The following is a description of a gene set: species: Homo sapiens Tumor growth is associated with a profound alteration of myelopoiesis, leading to recruitment of immunosuppressive cells known as myeloid-derived suppressor cells (MDSCs). Analyzing the cytokines affecting myelo-monocytic differentiation produced by various experimental tumors, we found that GM-CSF, G-CSF, and IL-6 allowed a rapid generation of MDSCs from precursors present in mouse and human bone marrow (BM). BM-MDSCs induced by GM-CSF+IL-6 possessed the highest tolerogenic activity, as revealed by the ability to impair the priming of IFN- -producing CD8+ T cells upon in vivo adoptive transfer. Moreover, adoptive transfer of syngeneic, GM-CSF+IL-6-conditioned MDSCs to diabetic mice transplanted with allogeneic pancreatic islets resulted in long term acceptance of the allograft and correction of the diabetic status. Cytokines inducing MDSCs acted on a common molecular pathway. Immunoregulatory activity of both tumor-induced and BM-derived MDSCs was entirely dependent on C/EBP transcription factor, a key component of the emergency myelopoiesis triggered by stress and inflammation. Adoptive transfer of tumor antigen-specific CD8+ T lymphocytes resulted in therapy of established tumors only in mice lacking C/EBP in myeloid compartment. These data unveil another link between inflammation and cancer and identify a novel molecular target to control tumor-induced immune suppression. We used gene expression analysis to identify those factors, secreted by tumor-infiltrating MDSC, which could drive emathopoiesis. Moreover we compare gene expression profile of tumor-induced MDSC, obtained from either the spleen and the tumor infiltrate of tumor bearing mice, and in vitro bone marrow-derived MDSC. from publication Marigo I, Bosio E, Solito S, Mesa C, Fernandez A, Dolcetti L, Ugel S, Sonda N, Bicciato S, Falisi E, Calabrese F, Basso G, Zanovello P, Cozzi E, Mandruzzato S, Bronte V (PMID 20605485) Human Gene Set: GSE21927_SPLENIC_C26GM_TUMOROUS_VS_BONE_MARROW_MONOCYTES_DN Genes down-regulated in CD11b+ cells from spleen of BALB/c mice bearing C26GM colon carcinoma versus CD11b+ cells from bone marrow of healthy BALB/c mice., and this is the list of marker genes: HS3ST3B1, SLC7A7, SCLT1, NDUFA3, MIF-AS1, C11orf68, MARCHF11, DENND2C, BASP1, MED21, TMTC4, ANKRD46, ORC4, BCL2L1, DNAJB12, TPGS2, XYLT2, ZNF558, POMGNT2, GRIN2B, CTNNA2, CEP164, PPP1CC, FOXN3, CD1D, GLRX5, FOXP1-IT1, CYBC1, ISG15, FRG1, GAB3, NUBP1, LHPP, USP4, PAK1IP1, PREP, NPHP3, SCAMP1-AS1 (SCAMP1 antisense RNA 1), GAPDHP62, RNGTT, BCS1L, RIMBP2, LIMS2, IFNAR1, KCNMB4, NPM3, CRELD1, GOLGA5, CECR7, ZFAND2A, GPR160, PALD1, ZFP82, NENF, FDX1, PLEKHG2, NEK8, C8orf33, NOS3, UTP18, ABI1, STAG3L4, SGK1, MTRES1, SLC4A7 (solute carrier family 4 member 7), DUSP3, FAM149B1, LIPA, NOP2, MRM2, ZNF521, NFIL3, ZNF790-AS1, SPMIP1, HINT1, HENMT1, NOTCH2NLA, ARHGAP26, MGST3, TMEM238, TNFRSF21, NXPH4, UBTD2, BHLHE40, SNRNP25, C10orf88, IFT52, SPATS2, FNTA, DDX31, CSRP1, FXN, NFATC2IP, ALDH18A1, RIMS3, DNAJB6, MAP3K20, NREP, CNFN, LSP1, CCDC97, RPL26L1, RGS7, PNLDC1, EI24, FEZ2, XK, COPS9, ANAPC11, SPMIP10, EP400P1 (EP400 pseudogene 1), CD86, ZNF34, CDC42BPG, CNTNAP3B, RHOBTB1, PPIF, PDIA6, SLC12A2, FUNDC1, HMGXB4, DOCK7, ANXA2, KCP, SUPT7L, DDX11L2, SLC35B4, CREG1, CDYL, BTN3A2, TSPYL5, ANTXR2, MYO19 (myosin XIX), HERC2, GDE1 (NCBI Gene Id 53591), FYTTD1, CNOT7 (CCR4-NOT transcription complex subunit 7), PTPN9, AKR7A2, ZNF823, VAV3, LRPPRC, CARF, DPPA3, SPTLC2, SEC61B, AHCYL2, GPLD1, STMN1, UHRF1, SSR3, GSR, TIMM13, EPRS1, LRRC57, DIO3, TMA16, COX5A, FAM167A, ZFYVE26, AP3M2, NMB, KLHL21, PDE4D, TUNAR, ZNF613, RAP2A, ANXA2P2, ANAPC4, TMEM87B, RP9, NAAA, ZNF35, RBPJ, ENSG00000290731, CCDC6, PRMT9, UAP1, GPR161, LINC00173, CHCHD7, KLHDC4, PUS7, LAPTM4B, MKRN2 (makorin ring finger protein 2), ZNF830, PDLIM2 (PDZ and LIM domain 2), NDUFA11, NMRK1, USP13, TMEM230